Given this list of marker genes Pold2, Rps27a, Rfc5, Pole4, Cul4b, Uba52, Uba52rt, Rfc2, Rfc3, Pole2, Wdr48, Rpa3, Pcna, Ubb, Pold3, Rpa2, Usp1, Pole, Pold1, Ubc, Rad18, Ube2b, Rfc1, Rfc4, Ddb1, Dtl, Pole3, Cul4a (NCBI Gene Id 99375, cullin 4A), Rpa1, Pold4, Rbx1, here is a description of the gene set: Mouse Gene Set: REACTOME_RECOGNITION_OF_DNA_DAMAGE_BY_PCNA_CONTAINING_REPLICATION_COMPLEX studied in species Mus musculus Recognition of DNA damage by PCNA-containing replication complex